Given this list of marker genes RAB25, CDC42EP4, SRGAP2C, SRGAP2, CDC42EP2, CDC42EP1, F2RL1, KIT (NCBI Gene Id 5086), CCR7, C15orf62, CDC42EP3, CDC42, WASHC1, CDC42EP5, APC, CCL21, here is a description of the gene set: A process that is carried out at the cellular level which results in the assembly, arrangement of constituent parts, or disassembly of a pseudopodium, a temporary protrusion or retractile process of a cell, associated with cellular movement. studied in species Homo sapiens Human Gene Set: GOBP_PSEUDOPODIUM_ORGANIZATION